Given this list of marker genes UGDH, PEX26, CLPB, DEAF1, GTF2E2, XPA, PIGY, KLHL9, ZFHX3, GALC, LMNA (NCBI Gene Id 7816), HESX1, MT-ND1, NECAP1, SELENON, SACS, SLC25A46, PRX, TPM3, CYFIP2, RMND1, DAG1, POMGNT2, FGD4, PEX3, SIL1, B4GALNT1, MYOT (NCBI Gene Id 9499), MT-ND3, NFASC, DBH, POLR3B, NRAS, GABRB2, SUCLG1, EGR2, CNTN1, HSPB1, LYST (NCBI Gene Id 1130), ACD, STIM1, GAA, PUM1, PNPLA6, COX6A1 (cytochrome c oxidase subunit 6A1), TTPA, IBA57, FXR1, DDB2, ADCY6, GABBR2, HINT1, ACOX1, TAOK1 (TAO kinase 1), PSMB8, SCN4A, DHH, RRM1, AK9, SETX, ATP11A, PPP2R5D, GFPT1, ADSS1, PRDM12, MFN2, PRNP, ATP6V1A, FBXO38, DUOXA2, LARGE1, CLCNKA, ERCC8, MEGF10, SCYL1, NDRG1, SNIP1, PGAP3, HSPG2, UBA1, IQSEC2, PPP3CA, ST3GAL5, DES, EMD, SNX14, PTRH2, MARS1, IARS2, PNPT1, FBLN5, COL13A1, SCN9A, PPP1R21, SCN11A, IFRD1, VAPB, OPA3, GEMIN4, GAN, FUS, RYR1, NOTCH2NLC (notch 2 N-terminal like C), KIF1A, NGLY1, CDK19, COG7, TSPYL1, DOCK3 (NCBI Gene Id 1795), HRAS, GABRA3, CNBP, PLA2G6, EXTL3, CPT1A, PDK3, AP3B2, COLQ, ATXN1, LHX3, GDAP1, SLC25A21, FKRP, GJB1, TOR1A, GABRA5, OPA1 (NCBI Gene Id 4976), GARS1, SLC9A1, PSMC1, ISCU, GABRA2, RRM2B, SLC12A6, EMC1, PLOD1 (NCBI Gene Id 5351), ALDH4A1 (NCBI Gene Id 8659), CAPRIN1, PIGN, CHRNB1, CLCNKB, RAB3GAP2, FBXO28, NEUROG1, ERGIC1, MT-ND2, PIK3R5, RMRP, PHKG1, PITX3, MT-ND6, TINF2, LRSAM1, REEP1, CARS2, PGAP2, LITAF, CHCHD10, HSPB8, PIGV, POU1F1, GMPPB, PEX16, ATP1A1, GLDC, DGUOK, TRMU, TSEN15, B4GAT1, COL12A1, MT-TL1, PEX6, XK, ERCC1, ITPR3, DYSF, PSAP, PDHB, FLRT1, MGME1, PRPS1, ALDH18A1, WARS1, SIGMAR1, NARS2, AMPD1, EXOSC1, PLAAT3, POMT2, ACAT1, TRIM32, NAGLU, KY, TIMM50, ATXN3, DUOX2, RNF170, COL4A1, AARS2, HADHA, SLC18A3, LAMB2, PRORP, EXOSC9, PEX1, ERCC2, KRAS, COQ4, SNUPN, ACADM, WWOX, MAGEL2, PMP22, NDUFA9, ITGA7 (integrin subunit alpha 7), SURF1, ANXA11, AR, COX8A, CHRNA1, PAX7 (NCBI Gene Id 5081), PIEZO2, TBK1, ATXN2, CRPPA, GIPC1, MT-TE, SCN1A, ARSI, MCM3AP, PARN, DNMT1, GEMIN5, ATP6AP2, VWA1, COG8, SMN1, HNRNPDL, NDUFS4, ATP6V1B2, GNAS, CACNA1A, VANGL1, SPTLC1, AARS1, MSTO1, KCNJ18, TUBA8, ALG6, MTMR14, KCNK9, FDX2, DNAJB2, QRICH1, MED25, ELOVL4, RNF113A, RTEL1, WNK1, ERBB3, LMOD3, PEX14, SLC5A5, JPH1, CACNA1B, TNNT1, LPIN1, ALG2, HADHB, SCN8A, PIGB, POMGNT1, CARS1, FLI1, GNPTAB, ITPR1, ATP1A2, YWHAG, JAG1, WDR81, XRCC1, DPYD, PIGW, MTPAP, ZSWIM6, SLC38A3, MPZ, FLII, PHKA1, ATP9A, C19orf12, HSPB3, ACO2, SLC1A3, TBCK, LRP4, B3GALNT2, SLC13A5, ABHD12, TAMM41, VPS33A (VPS33A core subunit of CORVET and HOPS complexes), DMD, GFER, GCSH, PLEKHG4, GBF1, CHRNE, PLEKHG5, SCN10A, KCND3, SPG11, CFL2, FHL1, HARS1, TPI1, TERT, MYL1 (NCBI Gene Id 90307), TRIP4, ATP7A, BSND, SUCLA2, COA7, TSHR, NDUFA1, PHYH, LHX4, GRIN2D, TECPR2 (NCBI Gene Id 9895), MT-TW, TARDBP, NEFL, POLG2, GTF2H5, PMM2, TYMP, RTN2, CNKSR2, DOK7, TMCO1, SLC1A2, SCYL2, SYT2, NDUFAF2, SYNE1, CRYAB, PROP1, HK1, FBN1, SNAP29, PPOX, NTRK2, TG, POMK, SLC35A1, LAMA2 (NCBI Gene Id 3908), DPM3, COL25A1, SLC5A6, AGTPBP1, SHANK3, CADM3, CCDC47, EXOSC8, PIGL, MT-ND4, PIGG, PTF1A, ARL6IP1, MAG (NCBI Gene Id 4099), FLNC (NCBI Gene Id 2318), RILPL1, NARS1, VPS13A, DNAJC3, AGRN, MDH2, PGM3, ASAH1, APTX, ACTL6B, NEFH, PLEC, TDP1 (tyrosyl-DNA phosphodiesterase 1), PEX7, TMEM240, ENTPD1, PLP1, SZT2, CLTC, PRDM13, MT-CO3, MYO9A, DST, FMR1, APOB, KCNA2, PEX10, HEXB, TRAK1, FKBP10, SLC25A4, MME, PEX19, RAB7A, SIM1, SYNE2, OCRL, FOXG1, ABHD5, ATN1, DKK1, SBF2, SLC52A2, SOX10, ABCA1, TRIM8, TTN, MT-ATP8, ASCC1 (activating signal cointegrator 1 complex subunit 1), LGI3, SCN3A, ARHGEF2, GBE1, CNTNAP1, ERCC3, LDB3, KLHL41, DNM1L, CD59, PACS2, IGHMBP2, DYNC1H1, ERCC4, MPV17, DHDDS (dehydrodolichyl diphosphate synthase subunit), PMPCA, MTRFR, MAP3K20, FUZ, MYH14, PMP2, HCN1, MYPN, GRIA3, MT-TT, INF2, MYH7, TRIM2, TFG, FXN, ACER3, UBAP2L (ubiquitin associated protein 2 like), TBC1D23, SPEG, GOSR2, MYORG, TAF1 (TATA-box binding protein associated factor 1), PNPLA2, ATP1A3, ERCC5, KCNC2, RNASEH1, MT-CO1, UBA5 (ubiquitin like modifier activating enzyme 5), DDC, FZR1, LRRK1, FAM111B, MRE11, DNASE1L3, YARS1, POMT1, TMEM43, RETREG1, BAG3, GLE1, IYD, LGI4, CACNA2D1, FLVCR1, SNRPN, CAV3, CELF2, SBF1, SPTLC2, VAMP1, ORAI1, MT-ATP6, CHAT, MYO1H (myosin IH), MTM1, CHRND, HSD17B4 (hydroxysteroid 17-beta dehydrogenase 4), ALDH5A1, CDK5, TWNK, DARS2, RAPSN, DPAGT1, TK2, PEX13, MT-ND5, ATXN10, PEX5, SCO2, VRK1, BICD2, PARS2, MT-TV, GNB4, FIG4, HMBS, CACNA1S, PEX12, OBSCN, KBTBD13, ATM, ALG1, PNKP, POLG, TTR, GNE, TRPV4, DNM1, GABRG2, RAI1, KARS1, ZC4H2, ARSA, ACTA1, TPO, PEX2, MORC2, RAP1GDS1, LRP12, SLC5A7, MTTP, ALG14, DCAF8, COASY, SAR1B, PYROXD1, HMGCL, SLC25A1, TPM2, ABCB7, HMGCR, RUBCN, NEB, ATL3, ERLIN1, FASTKD2, MUSK, TRIM37, TSHB, VCP, GBA1, DNM2, HDAC4, KIAA0586, EXOSC3, MYL2, PRKCG, RFC1, MT-TK, TBCD, PEX11B, STX16, TARS1, SEPTIN9, KIF1B, PDXK, KCNE3, MPLKIP, BEAN1, SPTAN1, DKC1, SH3TC2, TRMT5, KCNB1, ERCC6, XPC, TCAP, CNTNAP2, SQSTM1, LIFR, SNAP25, SMPD1, DALRD3, GRIN2A, RXYLT1, DHX16, DNAJC6, HACD1, AIFM1, TRAPPC11, STAC3, SPTBN4, SMN2, DHTKD1, TBC1D24 (NCBI Gene Id 57465), KLC2, COL6A1, FKTN, PODXL, SLC25A19, HNRNPK, DHX30, PDSS1, ELP1, FGF12, SYNGAP1, MYF6, NUS1, EEF1A2, PIGO, BIN1, SYNJ1, here is a description of the gene set: Reduced tendon reflexes Human Gene Set: HP_REDUCED_TENDON_REFLEXES Diminution of tendon reflexes, which is an invariable sign of peripheral nerve disease. studied in species Homo sapiens